Given this list of marker genes GNAS, AKT1, ATM, LZTR1, BICC1, ARMC5, BMPR1A, CDKN2B, GANAB, IDH2, USP48, KDM1A, NR3C1, TSC2, PMS1, PIK3CA, EPCAM (NCBI Gene Id 4275), CDKN1B, MEN1, RPS20, YY1, CDKN2C, MSH6, POLD1, COQ6, POLE, CDH23, TP53, PDGFB, SEMA4A, PKD1, PRKAR1A, DNAJB11, SMARCB1, MLH1, SMO (smoothened, frizzled class receptor), BAP1, TSC1, ALG9, SUFU, BRCA2, PKD2, IDH1, CDKN1A, BRAF, PDE11A, ALG5, TERT, TGFBR2, APC, SMARCE1, AIP, GPR101, USP8, IFNG, TRAF7, ATRX, KRAS, MUTYH, MSH2, NF2, PMS2, CTNNB1, IFT140, CHEK2, here is a description of the gene set: Human Gene Set: HP_NEOPLASM_OF_THE_ANTERIOR_PITUITARY A tumor (abnormal growth of tissue) of the adenohypophysis, which is also known as the anterior lobe of the pituitary gland. Neoplasm of the anterior pituitary studied in species Homo sapiens